Given this list of marker genes Rpp25, Pop4, Rpp40, Rpp21, Rpp25l, Rpp14, Prorp, Rpp30, Pop5, Pop7, Rpp38, Pop1, Ssb, here is a description of the gene set: studied in species Mus musculus Mouse Gene Set: GOBP_TRNA_5_LEADER_REMOVAL Generation of the mature 5'-end of the tRNA, usually via an endonucleolytic cleavage by RNase P.